The following is a description of a gene set: Mouse Gene Set: GOMF_PROTEIN_KINASE_ACTIVITY species: Mus musculus Catalysis of the phosphorylation of an amino acid residue in a protein, usually according to the reaction: a protein + ATP = a phosphoprotein + ADP., and this is the list of marker genes: Ppef2, Ksr1, Ryk, Cdkn1b, Atg13, Rad50, Afap1l2, Mapk8, Dele1, Raf1, Mark2, Prex1 (phosphatidylinositol-3,4,5-trisphosphate-dependent Rac exchange factor 1), Pask, Mup1, Tec, Brsk2, Pak4, Prkci, Snrk (SNF related kinase), Sbk2, Prkacb, Fgfrl1, Tnk2, Grk2, Nrp2, Map4k2, Rps6kb1, Dyrk2, Camkv, Nek5, Atad3a, Stk32c, Cad, Cdk16, Gucy2c, Plk1, Gucy2g, Inka2, Sostdc1, Cdk15, Ntrk1, Smo (NCBI Gene Id 319757), Ttbk1, Ephb4, Ngf, Cdc37, Sik3, Ccng1, Pkm, Pde8a, Prkx, Dgkq, Trib2, Bmx, Pkdcc, Dcaf1, Cdc7, Prkcz, Prkg1, Kit, Ulk1, Pak3, Ccnjl, Acvr1c, Adipoq, Tab1, Prkag2, Ajuba, Acvrl1, Jak3, Irak2, Cdk6, Alk, Sik2, Mknk2, Prkab1, Irgm1, Csnk1e, Mertk, Stk35, Gm14151, Ccnd1, Kidins220, Erbb4, Ror2, Nck1, Hjv, Dusp19, Prkaa2, Map3k10, Mob1b, Prkag3, Ccne1, Ccl3, Cdc42bpa, Pbk, Ripk3, Cdk20, Mast4, Pim1, Ccna1, Camk1, Mup2, Kat2b, Stk3, Tcl1b5, Stk36, Mst1r, Dclk2, Nme2, Axl, Hspb1, Baz1b, Obscn, Deptor, Mup11, Mup3, Syk, Gcn1, Plk3, Stk32a, Plk4, Nos2, Nolc1, Agap2, Mast3, Rac2, Camk2g, Stk31, Ern1, Prkdc, Ccni, Aak1, Chuk, Met, Pkib, Trp53rkb (transformation related protein 53 regulating kinase B), Stk39, Grk4, Pik3cb, Nek1, Lats1 (NCBI Gene Id 16798), Ros1, Haspin, Cd40lg, Stk10, Tyro3, Map3k2, Ttn, Cep43, Cdk7, Igf2, Alpk2, Pdk1, Tex24, Nrg1, Dyrk1a, Nuak2, Cdkl4, Ankrd42, Adck5, Wee2, Stk19, Prkar1b, Cnppd1, Erbb3, Mapk14 (NCBI Gene Id 26416), Gsk3a, Gprc5d, Cav1, Npr1, Ccng2, Spred2 (NCBI Gene Id 97717), Tom1l1, Pikfyve, Pak6, Irak1, Ddr1, Yes1, Abi1, Smok3a, Speg, Kalrn (kalirin, RhoGEF kinase), Limk2, Fgf13, Epha6, Ulk3, Ccdc88a, Pak1ip1, Mapk4, Clk4, Chek1, Map2k3, Camk2n2, Rheb, Dazap2, Epha7, Parp8, Ptk7, Ereg, Igf1, Pink1, Map3k14, Stk16, Elp4, Map4k1, Ccnt2, Als2, Wee1, Sgk3, Vegfa (vascular endothelial growth factor A), Aurka, Camk4, Cdkn2b, Ccl8, Ntrk3, Mapk11, Gsk3b, Hexim2, Phkg1, Prkag1, Ccnh, Cdkn2a, Sbk1, Dusp22, Atr, Avp (NCBI Gene Id 11998), Ahsg, Ddx3x, Cdkn1a, Cdk5, Lmtk2, Ddr2, Fes, 4921509C19Rik, 1810024B03Rik, Mob2, Tex14, Mapkapk5, Gm7168, Btc, Irgm2, Melk, Map2k2, Epha2, Ikbke, Mapk13, Calm2, Ripk1, Tssk4, Cdkn2d, Cdkl1, Rps6ka2, Ccnk, Mapk6, Rptor, Stk24, Trp53rka, Grk1, Itpka (NCBI Gene Id 228550), Nek7, Hunk, Grk6, Etaa1, Eif2ak4 (eukaryotic translation initiation factor 2 alpha kinase 4), Cib1, Matk, Alpk3, Mark3, Pan3, Hck, Hipk2, Ccnb1, Lrrk2, Spry2, Erbb2 (NCBI Gene Id 13866, erb-b2 receptor tyrosine kinase 2), Map4k4, Epha4, Mlst8, Nrk, Twf1, Tesk1, Frk, Srpk2, Gm7356, Cdc42bpb, Taok2, Myo3b, Txk, Mapk1, Gdf2, Ciita, Insr, Eif2ak1, Tnik, Nek6, Rps6ka3, Calm3, Camk2n1, Prag1, Bmpr2, Mlkl, Lck, Jak2, Rps6ka6, Gm4922, Cdk1, Rnasel, Prkcg, Mbip, Gucy2f, Ltf, Ccnj, Dapk1, Trim24, Mos, Inka1, Csnk2a1, Akt2, Cdk10, Stk40, Gprc5a, Mylk3, Pdk4, Spdya, Pak5 (NCBI Gene Id 73084), Src, Csnk1d, Myo3a, Macroh2a1, Pomk, Taok1, Hipk4 (homeodomain interacting protein kinase 4), Oxsr1, Mup4 (major urinary protein 4), Tnni3k, Bmpr1b, Map4k5, Aurkb, Ccnd3, Spry4, Ror1, Prkrip1, Camkk1, Rps6kl1, Ttbk2, Calm1, Ccno, Map2k6, Stk11, Pdgfrb, Fgfr2 (fibroblast growth factor receptor 2), Nim1k, Nek4, Ptk2, Mst1, Styk1, Ilk, Tek, Eef2k (NCBI Gene Id 97404), Abl2, Blk, Chka, Wnk2, Vrk1, Mapkapk2, Angpt4, Mok, Scyl2, Cks1brt, Top1, Casp3, Pdgfra, Slk, Pkia, Pkn2, Cd24a, Fgfr4, Pik3r4, Riok2, Nek11, Camk1g, Ywhab, Tlk2, Stk4, Mmd2, Stk25, Trpm6, Tyk2, Clk2, Rplp1rt, Hexim1, Cab39l, Srpk1, Dnajc3, Mark1 (NCBI Gene Id 98697), Smcr8, Ccny, Tssk5, Tcl1b2, Nek3, Cdkl5, Stkld1, Igf1r, Pdik1l, Fgfr1, Rps6kc1, Rictor, Ephb6, Stk33, Ptk2b, Il6st, Tcl1, Eif2ak3, Htra2, Rps6kb2, Map3k1, Prkd3, Lrrk1, Lilrb4b, Zap70, Cdk5r2, Lmtk3, Nek10, Chp1, Gprc5c, Akt1s1, Gprc5b, Mapk8ip2, Ripk2, Bmp2, Htr2a, Bmp2k, Wnk3, Epha1, Acvr2a, Cks1b, Ins2, Map2k1, Mtcp1, Nlk, Stk38l, Mark4, Stap1, Cdkn1c, Hipk1, Ccnq, Prkar2a, Alkal1, Ltk, Ccnl1, Cdkl3, Cdk19, Prkcq (NCBI Gene Id 99373), Cab39, Mapk9, Csnk2a2, Tesk2, Mnat1, Camk1d, Stradb, Adck2, Ankle2, Cdk5r1, Csnk2b, Acsl1, Parva, Scyl3, Fermt2, Rskr, Jak1, Itk, Nckap1l, Mob3c, Ankk1, Elp1, Nek2, Egfr, Csf1r, Pim3, Prkaa1, Stk17b, Tbk1, Fgr, Ibtk, Gm7358, Cpne3, Riok3, Lyn, Rock1, Bcr, Dbf4, Ephb2, Dus2, Tgfbr3l, Ptprc, Tssk2, Dyrk4, Mstn, Lilrb4a, Riok1, Epgn, Gskip, Sik1, Csnk1g1, Nek9, Btk, Mup5, Srms, Ly6g6e, Mast2, Ntrk2, Wnk1, Prkab2, Csnk1g3, Prkg2, Map2k5, Vrk2, Htatip2, Epha10, Tie1 (NCBI Gene Id 21846), Gucy2e (guanylate cyclase 2e), Phkg2, Mapk15, Map3k8, Map3k20, Akt3, Socs3 (NCBI Gene Id 12702), Trib1, Map4k3, Chek2, Mapk10, Pim2, Map3k9, Gak, Mob1a, Strada, Peak1, Ccnl2, Cdkl2, Pkmyt1, Cdk17, Nme7, Pgk1 (phosphoglycerate kinase 1), Atm, Map2k4, Nuak1, Trpm7, Pkig, Map2k7, Plk2, Tsacc, Ccna2, Mastl, Pik3cg, Grm5, Tssk6, Csnk1g2, Iqgap1, Ksr2, Ptk6, Rgcc, Epha5, Pskh1, Rack1, Cit, Hmgb1, Map3k21, Dapk2, Trio, Cks2, Fgfr3, Fam20c, Npm1, Mknk1, Bmpr1a (NCBI Gene Id 68748), Cdk4, Epo, Tbck, Dstyk, Mt3, Alkal2, Efemp1, Areg, Tlk1, Sgk1, Dyrk3, Slc27a1, Ulk2, D1Pas1, Gucy2d, Dapk3, Tnk1, Prpf4b (NCBI Gene Id 207915), Ccnt1 (NCBI Gene Id 72830), Flt3 (NCBI Gene Id 269731), Flt1, Camk2d, Map3k13, Map3k7, Pnck, Ghrl, Bub1, Bmp7, Scyl1, Inca1, Pik3c3, Ccnb1-ps, Map3k15, Hsp90ab1, Map3k11, Brd4, Tesc, Bub1b, Rps6ka1, Mapk7, Tgfbr3, Cdk13, Wnt11, Prkce, Map3k3, Prkd1, Ccnd2, Pkn1, Limk1, Vrk3, Ccnb3, Ednra, Grk3, Map3k12, Pck1, Lats2, Spred1, Sgk2, Map3k5, Dyrk1b, Abl1, Smok3b, Epha8, Grem1, Dmpk, Dab2ip, Cdk18, Stk32b, Mmd, Prkar1a, Mob3b, Prkra, Cdk12, Pdk3, Pik3ca, Coq8b, Rps6ka4 (NCBI Gene Id 68884), Topbp1, Brd2, Fyn, Pmp22, Tssk1, Cdkn2c, Samd15, Wnk4, Csk, Elp3, Cdk9, Stk38, Prkca, Brsk1, Hyal2, Flt4, Nbn, Qars1, Bckdk, Prkcd, Npr2, Ret, Prex2, Ulk4, Pdpk1, Ccnb2, Tcl1b1 (T cell leukemia/lymphoma 1B, 1), Acvr1b (activin A receptor, type 1B), Acvr1, Pdk2, Smok3c, Stk-ps2, Daxx, Pxk, Rassf2, Prkch, Mapk12, Tcl1b3, Cdk11b, Taok3, Dclk3 (doublecortin-like kinase 3), Cask, Cdk8, Aatk, Coq8a, Ins1, Mapkapk3, Parp6, Csnk1a1, Araf, Cdk3, Ccnc, Tcl1b4, Mak, Hbegf, Prkaca, Cdc42bpg, Musk, Cilk1, Prkcb, Stk26, Mob3a, Braf, Clk3, Taf1, Amhr2, Ern2 (endoplasmic reticulum to nucleus signalling 2), Nrbp1, Nrg2, Mylk, Ikbkb, Pkn3, Egf, Trib3, Grk5, Ankrd54 (ankyrin repeat domain 54), Map3k4, Rock2, Cdk14, Itprip, Fer, Ccl5, Ripk4, Irak3, Mylk4, Mapk3, Tssk3, Hspa5, Pak2, Hipk3, Irak4, Mink1, Map3k6, Alpk1, Tgfbr2 (transforming growth factor, beta receptor II), Srpk3, Ercc6, Sav1, Map3k19, Acvr2b, Camk2b, Ccne2, Mast1, Eif2ak2, Fam20a, Smok2a, Kdr, Ppp1r9b, Ccnf, Ephb1, Rplp1, Mylk2, Ttk, Blvra, Camk2a, Ephb3, Hk1, Lgals9, Smok2b, Uhmk1, Rps6ka5, Epha3, Camkk2, Adck1, Prkd2, Tgfa, Cdk2, P2rx7, Dclk1, Akt1, Nek8, Apc, Tgfbr1, Insrr, Smg1, Pak1, Sh3bp5, Trim28, Aurkc, Nrbp2, Clk1, Igtp, Sh3bp5l, Nrp1, Sbk3, Tgfb1, Prkar2b, Parp16, Bmp4, Fastk, Mtor